Given this list of marker genes RHCG, CCL4, STARD4, TNFAIP6, F8, GBP1 (guanylate binding protein 1), ANO5, RPGR, CCL20, SERPINB8, IL23A, ARHGEF2, ADM, TNIP3, RGCC, IL10, IL18, EREG, CD83, HAS1, DYRK3 (NCBI Gene Id 8444), EIF1B, NR4A2, TIFA, CSRNP1, SAV1, TNF, MMP7, CXCL5, ADTRP, WTAP, ELL2, PLEK, ACSL1, ID2, EGR1, ADORA2A-AS1, BTG3, REL, IL1B, IL36G, DNAJB4, PDE4B, DDX5, CXCL8, NLRP3, KDM7A-DT, IL6, SELENOK, E2F7, CASP5, SFMBT2, NFKBIZ, PELI1, GCH1 (NCBI Gene Id 93984), EDN1, CYB5D1 (cytochrome b5 domain containing 1), TXN, PIM3, PTGS2, PLA1A, NFKB1, ZC3H12A, CXCL1, IL1A, TAOK3, DLGAP1-AS2, PLK3, PLAUR, HES1, INHBA, NXT2, NEDD4L, CXCL2 (NCBI Gene Id 2920), ICAM1, FRMD7, NEMP1, DDIT4, RHOH, HIVEP2, DUSP2, JUN, PDSS1, CCDC59, ACOD1, GK, STK26, SIAH2, EGR3, LINC01465, BIRC3, PLEKHF2, HECW2, C11orf96, CLCF1, DENND5A, IER3, NAF1, PFKFB3 (6-phosphofructo-2-kinase/fructose-2,6-biphosphatase 3), MFSD2A, B3GNT2, F3, CFLAR, GBP2, PSMD5, ETS2, ERRFI1, RAPGEF2, CXCL3, RAB21, LINC01093, BTG2, TSC22D2, PPP1R15B, UBE2D1, AQP9, STAT5A, HNRNPC, ZNF674-AS1, SDC4, TFRC, CD274, NR4A3, ADAMDEC1, LINC00299, DUSP1, MAP3K8, IL20, SGPP2, TMEM88, USP12, MAP3K4, CCR7, NOCT, NFE2L2, DNAAF1, PTGER4, MSANTD3, PLD1, CCL18, PHLDA2, BCL2A1, ST20, NEK2-DT, SOCS3, GADD45A, MIR155HG, FOSL1, SOD2, RBBP8, SUSD6, PTX3, TNFAIP3, NUP58, YRDC, MSH6, MAFF, NBN, TPD52, STARD8, IL2RA, TLNRD1, PIGA, NFKBIA, CCRL2, CT75, ARL5B, DCUN1D3, GRAMD1A, POLR1F, AREG, G0S2, DUSP5, PTP4A1, GK3, PTS, LMOD1, PPP1R15A, GPR84, NR4A1, MIR3142HG, CDK1, SFR1, CSF3, GADD45B, TRIP10, DENND4A, ATP2B1-AS1, DLGAP1-AS1, RYBP, TP53BP2, RGS1, RND1, OTUD1, MIR3945HG, RIPK2, SCN1B, here is a description of the gene set: species: Homo sapiens Genes up-regulated in comparison of monocytes treated with 1 ng/ml LPS (TLR4 agonist) versus monocytes treated with control IgG. from publication Dower K, Ellis DK, Saraf K, Jelinsky SA, Lin LL (PMID 18292579) TREM-1 is an orphan immunoreceptor expressed on monocytes, macrophages, and neutrophils. TREM-1 associates with and signals via the adapter protein DAP12/TYROBP, which contains an immunoreceptor tyrosine-based activation motif (ITAM). TREM-1 activation by receptor cross-linking is pro-inflammatory, and can amplify cellular responses to Toll-like receptor (TLR) ligands such as bacterial lipopolysaccharide (LPS). To investigate the cellular consequences of TREM-1 activation, we have characterized global gene expression changes in human monocytes in response to TREM-1 cross-linking in comparison to and combined with LPS. Both TREM-1 activation and LPS up-regulate chemokines, cytokines, matrix metalloproteases, and PTGS/COX2, consistent with a core inflammatory response. However, other immunomodulatory factors are selectively induced, including SPP1 and CSF1 (i.e., M-CSF) by TREM-1 activation and IL-23 and CSF3 (i.e., G-CSF) by LPS. Additionally, cross-talk between TREM-1 activation and LPS occurs on multiple levels. While synergy in GM-CSF protein production is reflected in commensurate mRNA abundance, comparable synergy in IL-1b protein production is not. TREM-1 activation also attenuates the induction of some LPS target genes, including those that encode IL-12 cytokine family subunits. Whereas positive TREM-1 outputs are abolished by the PI3K inhibitor wortmannin, this attenuation is largely PI3K-independent. These experiments provide a detailed analysis of the cellular consequences of TREM-1 activation, and highlight some of the complexity in signal integration between ITAM- and TLR-mediated signaling. Human Gene Set: GSE9988_LOW_LPS_VS_CTRL_TREATED_MONOCYTE_UP